The following is a description of a gene set: Mouse Gene Set: GOMF_L_ALANINE_TRANSMEMBRANE_TRANSPORTER_ACTIVITY species: Mus musculus Enables the transfer of L-alanine from one side of a membrane to the other. L-alanine is the L-enantiomer of 2-aminopropanoic acid., and this is the list of marker genes: Sfxn1, Slc36a1, Slc36a3, Slc1a4, Slc3a2, Slc36a4, Slc7a8, Slc38a3, Slc36a2